The following is a description of a gene set: species: Homo sapiens Human Gene Set: GOCC_TRANSFERASE_COMPLEX_TRANSFERRING_PHOSPHORUS_CONTAINING_GROUPS A transferase complex capable of catalysis of the transfer of a phosphorus-containing group from one compound (donor) to another (acceptor)., and this is the list of marker genes: POLR2B, SNW1 (NCBI Gene Id 22938), GTF2H2C_2, LAS1L, PRKAB2, ATG101, TAF11L8, MAP3K5, TAF4B, PIK3R1, POLA1, LEO1, CKS1B, PRKAR2A, PRKAA1, CCNK, ERC1, CDK7, PIK3CG, AKAP14, ZBTB7A, GMPPA, TAF12, GTF2E1, RB1CC1, CDK8, TRAF3, CDK14, POLD1, CDK11A, CCNG2, CCNI2, POLR2J2, PRKACG, PCNA, ATG14 (NCBI Gene Id 22863), TAF6L, STRADA, POLG, PHKB, TBP, TAF5, MYZAP, CCND3, CCNJ, IKBKE, RB1, BCCIP, UGT3A2, PRIM2, PIK3CB, CDK13, CSNK2A1, TAF5L, TAF9, RPAP1, TRIM40, STING1 (NCBI Gene Id 340061), CTR9, PFKL, ERCC3, CCNE1, CHUK, PRIMPOL, CDKN2D, CAB39, TGFBR1, CDK5R2, POLR2J3, STK11, RICTOR, PIK3R4, PRKAG3, CCNP, TAF9B, ERCC2, XRCC5, PFKM (phosphofructokinase, muscle), CCNL2, CCNO, GTF2H1, CDKN1A, PFKFB1, POLA2, NEK10, TAF11L11, IFIT5, CCNY, ATG13, MED13, TAF2, GTF2E2, CCND2, TAF7L, TGFBR2, POLR3B, EXT2, GTF2A2, MMS19, PHKG1, POLR3H, SKIC8, CDK6, CSNK2A3, PRKACB, PRKY, POLE4, TAF11L14, CCNE2, GTF2F2, POLR3D, PARD3, CDK1 (cyclin dependent kinase 1), PHKA1, TAF13, TERC, TENT2, GTF2H5, MLST8, ULK1, TBC1D5, PAF1, IKBKG, PRPS1L1, GTF2H2C, PRKAG1, POLR1D, ERN1, CDK19, ALG13, AKAP4, TAF1, TRRAP, PSG9, POLR3E, GTF2H4, POLR2I, AZI2, BECN1, PIK3CA, PHKG2, GTF2H3, PIK3CD, POLR1F, POLR2D, TADA3 (NCBI Gene Id 10474), POLR3GL, CAB39L, ALG14 (NCBI Gene Id 199857), GMPPB, GNPTG, POLD4, CCNB3, MCM3, RTF1 (NCBI Gene Id 23168), ATXN7L3, CCNA1 (NCBI Gene Id 8900), PKLR, CDK9, POLR1A, PIK3R3, PRKX, CRCP, PEX2, DBF4, CCNA2, CCNJL, UVRAG, POLR2M, CNPPD1, PRKAA2, TAF11L9, TANK, IKBKB, PFKP (NCBI Gene Id 5214), PRIM1, POLR2J (RNA polymerase II subunit J), GTF2H2, INSR (NCBI Gene Id 3643), MNAT1, CCNT1, POLR3F, POLRMT, PRKAR2B, GTF2B, POLR1B, PHKA2, TAF11L3, CCNG1, PRKAG2, ACVR1, TCEA1, POLE2, GTF2F1, CSNK2A2, POLR2C, POLR3C, POLD3, ACVR2A, REV3L (NCBI Gene Id 7807), TAF11L10, TAF7, TAF8, CCNH, PIK3R5, SESN2, CCNI, DBF4B, STRADB, CDK10, UGT3A1 (NCBI Gene Id 133688, UDP glycosyltransferase family 3 member A1), MAPKAP1 (NCBI Gene Id 79182), C9orf72, XRCC6, CDK4, TAF3, ATXN7, PARD6A, POLD2, POLR3G, CKS2, PRKACA, DNA2, TAF11L4, TAF11L13, CCNB1, CHRAC1, POLR2K, PRPS1, CCNB2, TBPL1, GTF2A1, TAF11L2, ACVR1C, BECN2, MTOR, PRKAR1B, CSNK2B, ZNFX1, CCNT2, MED12, TAF11, USP22, CCNF, ACVR2B, POLE, POLR2E, PIK3R2, CDK2, TAF10, RPTOR, PAAF1, PIK3R6, PYCARD, TAF11L7, TAF4, CDK12, TUFT1, POLR2H, POLR1E, ENY2, TBKBP1, PRKCZ (NCBI Gene Id 5590), POLR2L, CCND1, POLR3K, TAF1L, TAF11L12, PIK3C3, PRKAR1A, KAT2A, TAF6 (NCBI Gene Id 6878), POLE3, CDC73, SUPT3H, POLG2, POLR2F, TERT, PARD6B, PRKDC, DAPK1, CDK5, PRKAB1, IRS1, CDK5R1, INSRR, CDK11B, PRKCI, CCNL1, CCNQ, IGF1R, GTF2A1L, PYDC1, CDK3, ACVR1B, TAF11L6, NRBF2, POLR3A, VAC14, SMCR8, MAD2L2, TBK1, POLR2G, POLR1C, CDK16, POLR1G, POLR2A, PARD6G, CCNC, POLR1H